The following is a description of a gene set: Human Gene Set: HP_INCREASED_SERUM_TESTOSTERONE_LEVEL An elevated circulating testosterone level in the blood. Increased serum testosterone level species: Homo sapiens, and this is the list of marker genes: NR2F2, AR, FSHR, WNT4, PRKAR1A, POLR3A, GNAS, INSR, CYP11B1, NR3C1, HSD3B2